The following is a description of a gene set: Genes down-regulated in endothelial cells: untreated versus exposed to E. burgdoferi. Human Gene Set: GSE6092_CTRL_VS_BORRELIA_BIRGDOFERI_INF_ENDOTHELIAL_CELL_DN Borrelia burgdorferi, the agent of Lyme disease, promotes pro-inflammatory changes in endothelium that lead to the recruitment of leukocytes. The host immune response to infection results in increased levels of IFN-gamma in the serum and lesions of Lyme disease patients that correlate with greater severity of disease. Therefore, the effect of IFN-gamma on the gene expression profile of primary human endothelial cells exposed to B. burgdorferi was determined. B. burgdorferi and IFN-gamma synergistically augmented the expression of genes, seven of which encode chemokines. Six of these (CCL7, CCL8, CX3CL1, CXCL9, CXCL10, and CXCL11) attract T lymphocytes, and one (CXCL2) is specific for neutrophils. Synergistic production of the attractants for T cells was confirmed at the protein level. IL-1beta, TNF-alpha, and LPS also cooperated with IFN-gamma to induce synergistic production of CXCL10 by endothelium, indicating that IFN-gamma potentiates inflammation in concert with a variety of mediators. An in vitro model of the blood vessel wall revealed that an increased number of human T lymphocytes traversed endothelium exposed to B. burgdorferi and IFN-gamma, as compared to unstimulated endothelial monolayers. In contrast, addition of IFN-gamma diminished the migration of neutrophils across B. burgdorferi-activated endothelium. IFN-gamma thus alters gene expression by endothelium exposed to B. burgdorferi in a manner that promotes recruitment of T cells and suppresses that of neutrophils. This modulation may facilitate the development of chronic inflammatory lesions in Lyme disease. from publication Dame TM, Orenzoff BL, Palmer LE, Furie MB (PMID 17202382) studied in species Homo sapiens, and this is the list of marker genes: GSPT2, ITSN1, SORCS1, NEK8, IRS2, NNAT, DDX50, TEX14, CFAP20, SLC3A2, PNRC1, NR1D2, CD274, SCN4B, LRRC15, IFNA5, SERTAD1 (NCBI Gene Id 29950), CCNL2, ADRM1, UBC, POLR1G, ARID5A, FAHD1, MYO6, CDK12, CTLA4, MUC1, TNFAIP3, DNAJC12, CYLC2, DMTF1, RNF183, PQBP1, ARL5B, PRSS46P, NXF1, KRT15, CLDN3, DUSP3, MUC3A, PRPF6, GLUD1, ETS2 (ETS proto-oncogene 2, transcription factor), COTL1, ZFAND2A, CCDC121, NRG3 (NCBI Gene Id 219505), HIP1R, PRTG, LONRF3, GRB7, CXCR4 (C-X-C motif chemokine receptor 4), NFKBIA, VSTM2L, VPS37B, DUSP4, PPP1R11, CCNL1, SOWAHB, RPL4, ISG20, APLN, GADD45B, METTL6, RAMP2, ISG15, PSD, IER5, RGS9BP (regulator of G protein signaling 9 binding protein), RGS9 (NCBI Gene Id 8787), SERTAD4, GHITM, SHISA6, PER1, NLE1, SLC2A5, NR4A2, SQSTM1, GPER1, GPR183, KLRC2, ZFC3H1, MEF2D (myocyte enhancer factor 2D), NKX2-5, ATG16L2, PLK2, DTNBP1, ZCCHC14, PFKP, NFKBIE, CUBN (NCBI Gene Id 8029), KLHL2, PRKCSH, PLD5, FZD3, SCEL, CHD2, ZC3H11A, SFTPB, CYP27B1, ETV3, NACA, ADIG, TDP2, GCH1, DLX3, TMEM63B, NDUFS5, PVR, KDM6B, RPS19BP1, TRA2B, SDE2, SF1, CLK4, CABP1, GK5, TPD52L2, ACSBG1, MST1R, IER5L, WNK1, GPR132, CCDC9, HFM1, F10, NPNT, TNFRSF10B, EGR4, LHX3, PLAUR, MC3R, TGIF1, MED11, LCN8, CTSLP3, TINF2, OMG, ING3, RORA, PWWP2B, SCN3A, HSP90AA1, MAFK, GPX2, GNG4, MAFG, ATF3, GPR4 (NCBI Gene Id 2828)